The following is a description of a gene set: species: Homo sapiens SARS-CoV-2 altering angiogenesis via NRP1 Human Gene Set: WP_SARSCOV2_ALTERING_ANGIOGENESIS_VIA_NRP1, and this is the list of marker genes: NRP1, ACE2, VEGFA, KDR, FURIN